Given this list of marker genes Hif1a, Mrs2, Slc25a12, Ldhal6b, Ldhd, Slc37a4, Park7, Actn3, Glo1, Ldhc, Mtch2, Pnkd, Tigar, Pfkfb2, Per2, Ldhb, Gatd1, Htt, Hagh, Trp53, Haghl, Ldha (NCBI Gene Id 16828), here is a description of the gene set: studied in species Mus musculus Mouse Gene Set: GOBP_LACTATE_METABOLIC_PROCESS The chemical reactions and pathways involving lactate, the anion of lactic acid.